Given this list of marker genes HLA-A, TLR4, porB, TAPBP, HLA-F (NCBI Gene Id 3134), MRC2, IKBKG, HLA-B, MYD88, TLR1, BTK, HLA-H, S100A1, PSMA7, CD36, PSMD12, TAP2, HMGB1, FGA, LY96, PSMB4, SEM1, S100A9, PSMA5, PSMC5, CYBA, PSMA2 (proteasome 20S subunit alpha 2), IKBKB, SNAP23, PSMA3, PSMB10, CTSV, mip, PSMD7, SEC61A2, PSME2, PSMB7, HLA-C, PSMB2, SEC61A1, PSMC4 (NCBI Gene Id 5704), NCF4 (NCBI Gene Id 4689), PSMD6, FGG, CHUK, UBB, CYBB, HLA-G, TIRAP, ITGAV, S100A8, UBC, PDIA3, PSMA6, PSMB9, PSMD11, PSMB1, FCGR1A, PSMD14, SEC61B, VAMP8, B2M, PSMB6, CD207, ITGB5, NCF1, UBA52, PSMB8, PSMD1, PSMD8, LNPEP, CTSS, PSMD13, VAMP3, TAP1, NCF2, TLR6, CD14, PSMC6, SEC61G, PSMC3, RPS27A, TLR2, PSMA4, PSMA1, PSMB5, HLA-E, PSMD3, PSMD2, MRC1, PSMC1, FGB, STX4, ADRM1, PSME1, PSMC2, PSMB3, CTSL, FCGR1BP, CALR, SEC22B, here is a description of the gene set: MHC class I molecules generally present peptide antigens derived from proteins synthesized by the cell itself to CD8+ T cells. However, in some circumstances, antigens from extracellular environment can be presented on MHC class I to stimulate CD8+ T cell immunity, a process termed cross-presentation (Rock & Shen. 2005). Cross-presentation/cross-priming is the ability of antigen presenting cells (APCs) to present exogenous antigens on MHC class I molecules to CD8+ T lymphocytes. Among all the APCs, dendritic cells (DC) are the dominant antigen cross presenting cell types in vivo, although macrophages and B cells appear to cross present model antigens in vitro with a low degree of efficiency (Amigorena & Savina. 2010, Ackermann & Peter Cresswell. 2004). Compared to macrophages, DCs have low levels of lysosomal proteases and exhibit limited lysosomal degradation. This limited proteolysis of internalized antigens by DCs might contribute to their high efficiency for cross-presentation (Monua & Trombetta. 2007). APCs acquire the exogenous antigens through endocytic mechanisms, especially phagosomes for particulate/cell-associated antigens and endosomes for soluble protein antigens. There does not seem to be a unique pathway for cross-presentation but rather different potential mechanisms of cross-presentation have been proposed. These proposed pathways can be classified according to the location where two key events occur: 1) processing of the antigenic protein and 2) loading of the processed peptide on to MHC I molecule (Blanchard & Shastri. 2010). Based on the requirement for TAP and cytosolic proteases two mechanisms have been described, a cytosolic pathway (TAP-dependent and proteasome-dependent) or a vacuolar pathway (TAP- and proteasome-independent) (Blanchard & Shastri. 2010, Amigorena & Savina. 2010). Regarding peptide-loading, MHC I could be loaded in the ER or in the phagosome and recycled to cell surface (Blanchard & Shastri. 2010). Exogenous soluble antigens are cross-presented by dendritic cells, albeit with lower efficiency than for particulate substrates. Soluble antigens destined for cross-presentation are taken up by distinct endocytosis mechanisms which route them into stable early endosomes and then to the cytoplasm for proteasomal degradation and peptide loading. The outcome of the cross-presentation can be either tolerance or immunity (Rock & Shen. 2005). part of: Class I MHC mediated antigen processing & presentation Reactome Pathway: Antigen processing-Cross presentation species: Homo sapiens